The following is a description of a gene set: species: Mus musculus Catalysis of the hydrolysis of a lipid. Mouse Gene Set: GOMF_LIPASE_ACTIVITY, and this is the list of marker genes: Abhd1, Pla2g7, Sec23ip, Apoc3, Pla2g4b, Lipe, Ddhd1, Apoh, Pnpla7, Abhd16a (NCBI Gene Id 53772), Faah (fatty acid amide hydrolase), Smpdl3a, Cel, Apoc2, Plbd2, Plcg1, Ccl5, Plcd3, Gpihbp1 (NCBI Gene Id 68453), Pld2, Smpd4, Liph, Fyn, Lpl, Smpd3, Apoa2, Smpd1, Nsmaf, Pla2g2f, Pla1a, Eed, Gm8978, Pld1, Ces1d, Plcg2, Btk, Proca1, Plcz1, Lipo2, Gm2a, Abhd12b, Plbd1, Pld3, Pnlip, Arf4, Lipc, Pla2g4c, Pnpla3, Enpp7, Aspg, Smpd5, Prdx6b, Lipg, Lipn, Ces1h, Hras, Plcb4, Lipo3, Ces1b, Pla2g12a, Casp3, Pdpk1, Angptl3, Lipi, Lcat, Ddhd2, Lipo4, Pnpla2, Abhd12, Plcd1, Pdgfra, Enpp2, Stx4a, Pnpla5, Pla2g12b, Pla2g2d, Ppt1, Gdpd5, Pld6, Apoc2l, Prdx6, Lipa, Pla2g5, Arhgap6, Pnpla6, Dagla, Pinlyp, Pld4, Ccl3 (NCBI Gene Id 20302), Abhd5, Gde1, Ccr1, Oc90, Apoc1 (apolipoprotein C-I), Apoa1, Pla2g4e, Src, Ces1f, Aadac, Pla2g3 (phospholipase A2, group III), Plcb2, Pla2g2a, Ces1e, Abhd11, Plch1, Scgb1a1 (secretoglobin, family 1A, member 1), Arf1, Abhd4, Ces1g, Pla2g4d, Lypla1, Abhd2, Arl1, Pnliprp1, Plb1, Plcb1, Abhd3, Ces1a, Pgap6, Napepld, Mgll, Anxa1, Plaat5, Ccl8, Gpld1, Apoa5, Gdpd3, Smpd2, Pnpla1 (NCBI Gene Id 433091), Anxa3, Hmox1, Lypla2, Ccr1l1 (NCBI Gene Id 12770), Lipo1, Pla2g2c, Plcb3, Plaat1, Pla2g6, Plaat3, Lck, Pnliprp2, Pnpla8, Plaa, Alkbh5, Pla2g15, Plcd4, Pla2g4a, Smpdl3b, Plch2, Ldah, Daglb, Abhd6, Faf2, Abhd16b (abhydrolase domain containing 16B), Abhd15, Pla2g4f, Pla2g2e, Notum (NCBI Gene Id 77583), Plcl1, Pla2g1b, Ces1c, Plcl2, Anxa2, Pla2g10, Lipf, Pitpnm3, Gdpd1, Plce1